The following is a description of a gene set: IRAK-4 is an essential component of the signal transduction complex downstream of the IL-1- and Toll-like receptors. Though regarded as the first kinase in the signaling cascade, the role of IRAK-4 kinase activity versus its scaffold function is still controversial. In order to investigate the role of IRAK-4 kinase function in vivo, ‘knock-in’ mice were generated by replacing the wild type IRAK-4 gene with a mutant gene encoding kinase deficient IRAK-4 protein (IRAK-4 KD). Analysis of bone marrow macrophages obtained from WT and IRAK-4 KD mice with a number of experimental techniques demonstrated that the IRAK-4 KD cells greatly lack responsiveness to stimulation with the Toll-like receptor 4 (TLR4) agonist LPS. One of the techniques used, microarray analysis, identified IRAK-4 kinase-dependent LPS response genes and revealed that the induction of LPS-responsive mRNAs was largely ablated in IRAK-4 KD cells. In summary, our results suggest that IRAK-4 kinase activity plays a critical role in TLR4-mediated induction of inflammatory responses. species: Homo sapiens from publication Koziczak-Holbro M, Glück A, Tschopp C, Mathison JC, Gram H (PMID 18266302) Human Gene Set: GSE9037_WT_VS_IRAK4_KO_BMDM_DN Genes down-regulated in comparison of untreated wild type macrophages at 4 h versus those from IRAK4 deficient mice at 4 h., and this is the list of marker genes: CCND1, OST4, HRH4, ATP10B, CDK2, RANBP3, DCSTAMP, G3BP1, TBX22, TTL, BLVRA, LPGAT1, PROC, HEATR5A, AGT, HPCA, STYXL2, PCLAF, LUM, PIF1, WDR24, IAPP, SLC4A1, PKMYT1, SOWAHA, ASB2, TSPAN14, NRM, COX4I1, DHFR, SMC2, ALPK1, TCTN3, STK32A, MCEE, TGM2, IFT22, CENPK, NCF1, GALNT9, NRG4, CALB1, MYO7B, ANKRD37, GARIN5A, LCN9, MMP17, FAM217B, BLNK, MTCH1, TPRA1, CARM1, HSPB9, LGALS9B, SDF2L1, TFAP2E, NTF3, GSDMD, NAP1L2, VCP, FGF3, BIK, NPY1R, STAP1, TMPRSS5, HAT1, IL2RA, SPTBN4, APMAP, NPTX1, MYO1C, CRAT, RBM11, S100A11, SORT1 (NCBI Gene Id 6272), FKBP1B, RFX8, ABCB4 (ATP binding cassette subfamily B member 4), WNT6, RAB21, DAGLB, MCEMP1, MTCL3, GLB1L2, SFTPA1, MRPL12, BLOC1S1, TENT4A, AKT3, SMCO3, SH3RF2, PPP4R4, MUC4, DDI2, MYOM2, ACOT8, BTBD1, CD79A, OAS3 (2'-5'-oligoadenylate synthetase 3), TMEM163, DDX18, A1CF, RXFP1, POLR2I, DHX40, ITGBL1, ART5, AIF1, ESYT1, ZNHIT2, MAF1, TRIM65 (NCBI Gene Id 201292), NPM1, IER5 (NCBI Gene Id 51278), CFAP47, LSP1, CKB, RAPGEF5, DLX4, GP9, TEX48 (NCBI Gene Id 100505478), COX8A, PPIH, TMEM198, CENPQ, CCSER1 (NCBI Gene Id 80730), CGREF1, TENM1, MACROD2, FAM110D, CNMD, ITPK1, NUSAP1, CKAP4, MYCN, HDAC9, CR1L, FGF11 (NCBI Gene Id 2256), FAM3D, FGF1, IGF2BP2, LIM2, CYB5R4, SH2D5, FIS1, MELTF, SPTB, CDCA3, COX10, TBRG1, LIAT1 (ligand of ATE1), PGBD1, CLEC7A, GABRA5, GRAMD2B, PSMB10, SLC15A3, TNNT3, POF1B, ODAD4, GMFG, BMPR2, CCNQ, YBX1, PLEKHM1, LSM3, IL20, CBX5, AP1S2, ZNF471, CLDN15, CARTPT, CD27, RAD51, ERCC4, RTRAF, DSP, ATP6V1B2, TACC3, TXNDC2, CBR3, C1QTNF7, C4orf17, CCDC7, ABCC6, PLD4, LXN, CCNF, PRDX5, ANKRD33, PTH, JARID2, FXYD2, OGFOD2, CRABP2, MC1R, IQCA1, RNF103, OAS1, PEX14